Given this list of marker genes CHSY1, SULT1B1, SULT6B1 (sulfotransferase family 6B member 1), SULT2B1, EXT2, SULT1C2, SULT1C4, HS3ST5, SULT1A1, SULT1A4, SULT4A1, SULT1A2, SULT1C3, CHST4, SULT1E1 (sulfotransferase family 1E member 1), EXT1, SULT2A1, TPST2, SULT1A3, CHST5 (carbohydrate sulfotransferase 5), here is a description of the gene set: The addition of a sulfate group to a molecule. species: Homo sapiens Human Gene Set: GOBP_SULFATION